Given this list of marker genes PRDX6, CES3, SLC39A2, SLC2A14, SERPINA1, SLC6A20, SLC2A12, GCLM, GSTT2, SLC5A1, ABCC4, CBR3, SLC6A13, GCLC, SLC5A4, SLC2A10, GSTA3 (glutathione S-transferase alpha 3), DNAJB1, SLC2A5, TGFB2, UGT2B7, HSP90AA1, AGER, GSTA4, GSR, SLC6A4 (NCBI Gene Id 6532), CES2, GSTA1, GSTM3, GPX3, SQSTM1, SLC39A12, SLC2A3, TGFA (transforming growth factor alpha), SLC2A13, NQO1, UGT1A9, GSTP1, SLC5A12, TGFB1, HBEGF, TXN, ALDH3A1, SRXN1, SLC39A10, PTGR1, ABCC2, MGST2, GSTM4, SLC6A18 (NCBI Gene Id 348932), ABCC5, SLC6A15, ABCC3, CYP4A11, CBR1 (carbonyl reductase 1), CES5A, G6PD, PGD, PPARD, SLC6A2, SLC6A11, EPHA2, PRDX1, SLC5A8, SLC39A1, SLC6A17, BLVRB, SLC6A14, SLC39A5, SLC5A7, PDGFB, SLC6A6, GSTM5, CES1, UGT1A4 (NCBI Gene Id 54657), SLC2A6, GSTM2, UGT1A6, SLC39A7, GPX2, SLC5A9, HGF, SLC39A8, SLC2A1, UGT1A7, NRG1, FTH1, CES4A, SLC5A5, SLC39A13, GSTA2, EGR1, MAFG (MAF bZIP transcription factor G), TXNRD3, SLC39A3, SLC39A11 (NCBI Gene Id 79399), SLC2A7, HMOX1, SLC2A4, SLC2A2, SLC6A16, HSP90AB1, NFE2L2, SLC6A19, HSPA1A, SLC7A11 (NCBI Gene Id 23657), SLC5A2, GGT1, RXRA, UGT1A1, SOD3, FTL, CYP2A6, ADH7, SLC2A11, SLC39A14, SLC6A1, SLC5A3, SLC5A10, SLC2A9, SLC6A3, SLC6A9, SLC5A11, FGF13, MAFF, GSTA5, SLC5A6, TGFBR2, SLC6A8, SLC39A6, SLC39A4, SLC6A7, SLC2A8, KEAP1, ME1, SLC39A9, MGST3, SLC6A5, EPHA3, GSTM1, TXNRD1 (NCBI Gene Id 7296), here is a description of the gene set: Human Gene Set: WP_NRF2_PATHWAY NRF2 pathway species: Homo sapiens